The following is a description of a gene set: Human Gene Set: GOBP_NEGATIVE_REGULATION_OF_PROTEOLYSIS_INVOLVED_IN_PROTEIN_CATABOLIC_PROCESS species: Homo sapiens Any process that stops, prevents or reduces the frequency, rate or extent of proteolysis involved in protein catabolic process., and this is the list of marker genes: TRIM39, RPL5, PML, PARK7, MTM1, ARHGAP5-AS1, HIPK2, N4BP1, QRICH2, HFE, USP7, MAP1A, F8A2, PABPN1L, PHF20L1, UBXN2A, EPHA4, HSP90AB1, EIF3H, DDRGK1, SGTA, F8A1, SUFU, RPL23, OGT, PSMF1, MARCHF7, SMARCC1, TTC36, ALAD (NCBI Gene Id 210), F8A3, OPHN1, EFNA1, RPS7, PANO1, PSME3IP1 (NCBI Gene Id 80011), CDKN2A, UFSP2, USP26, BAG6, PRMT6, BAG5, KLHL40, CAMLG, AQP11, SHH, PRKCG, USP14, PBK, MIR128-1 (NCBI Gene Id 406915), USP38, RYBP, CCAR2, RPL11, UBXN1, UCHL5, CSNK2A2, PDCL3, SENP1, TAF1, NOP53, FHIT, WNT1, PSEN1, STYX, TLK2, GABARAPL2 (GABA type A receptor associated protein like 2), CSNK2B, USP9X, LAMP3, USP5, WAC, SVIP, USP25, CSNK2A1, GIPC1, TAF9